The following is a description of a gene set: Any process that results in a change in state or activity of a cell or an organism (in terms of movement, secretion, enzyme production, gene expression, etc.) as a result of a sodium arsenite stimulus. studied in species Mus musculus Mouse Gene Set: GOBP_RESPONSE_TO_SODIUM_ARSENITE, and this is the list of marker genes: Hsf1, Mapk13, Nefh, Hnrnpa1 (NCBI Gene Id 52621), Daxx, Atg7, Nefl, Lonrf2, Zc3h12a